The following is a description of a gene set: Reactome Pathway: Signaling by phosphorylated juxtamembrane, extracellular and kinase domain KIT mutants species: Homo sapiens part of: Signaling by KIT in disease Activation of the PI3K/mTOR, RAS/MAPK and STAT signaling pathways has been observed downstream of activated extracellular, juxtamembrane and kinase domain mutants of KIT, although downstream signaling has not been studied in great detail in all cases. Activation of these pathways contributes to cellular proliferation, avoidance of apoptosis, and actin cytoskeletal organization., and this is the list of marker genes: KIT, SRC, GRB2, NRAS, SOS1, KRAS, HRAS, JAK2, PIK3CA, STAT1 (signal transducer and activator of transcription 1), STAT5A, PIK3R1, FYN, PIK3R3, LYN, LCK, STAT5B, YES1, PIK3R2, STAT3 (NCBI Gene Id 6774)